The following is a description of a gene set: Human Gene Set: HP_FEMORAL_HERNIA A hernia which occurs just below the inguinal ligament, where abdominal contents pass through a naturally occurring weakness called the femoral canal. Femoral hernia studied in species Homo sapiens, and this is the list of marker genes: ATP7A, PTDSS1, WNT5A, SMAD4, DIS3L2, SLC2A10, DVL3 (dishevelled segment polarity protein 3), EHMT1, COL1A2, TBX1, COL1A1, ADAMTS2, FZD2, CAMSAP1, SLC26A2, ADAMTSL2, DVL1, FANCB, EFEMP1, TRIP11